Given this list of marker genes Eif2s3y, Eif2s1, Eif2s3x, Eif2a, Eif2b1, Eif2s2, here is a description of the gene set: studied in species Mus musculus Complex of three heterogeneous polypeptide chains, that form a ternary complex with initiator methionyl-tRNA and GTP. This ternary complex binds to free 40S subunit, which subsequently binds the 5' end of mRNA. Mouse Gene Set: GOCC_EUKARYOTIC_TRANSLATION_INITIATION_FACTOR_2_COMPLEX